Given this list of marker genes F2RL2, C3orf52, GNG3, SRSF9, MPPED2, MNT, CXXC5, PHC1, DTL, CAMK2N1, SLC18B1, HNRNPK, SHISA6, SIAH2 (siah E3 ubiquitin protein ligase 2), LCP1, PCLAF, TRIB1 (tribbles pseudokinase 1), DMXL2, CHPT1, PPM1G, JUP, DRAP1, PTBP1, DCLK3, BASP1-AS1, PTGES, MLXIP, STARD13, CCDC191, SOX30, SYNCRIP, MAFG, BAZ2B (bromodomain adjacent to zinc finger domain 2B), PEDS1, RCBTB1, USP47, RELL1, BAHD1, TMX3, LEF1, ADNP, HDHD2, DIRAS2, EEF1G, CAP2, MME, MAP3K21, MZB1, ITFG2, HMCES, ACTG1, PHF10, TRIM35 (tripartite motif containing 35, NCBI Gene Id 23087), NUP88, LIMS2, TPD52, MIR663AHG, AKAP12, TCL1A, F2RL3, HERC2P1, DCBLD1, HNRNPA2B1, RASSF6, SSRP1, AAK1, HSPD1, PLEKHB2, AEBP1, ARHGAP17, SUCLG2, HRK, MCF2L2, URB2, KCTD3, SH2D1A, UBE2M, DIMT1, NOC2L, RB1, SLC38A1, TSPAN14, FGGY, DCAF12, BEST4, NNT, BTBD3, HERC2, SOX8, TAS2R38, SMAD1, ING5, KCNJ2, THTPA, LNPEP, CAMKK2, DHX9, LONRF2, ZWINT, ENO2, IFT52, ZNF41, ANKS1A, GNAI1, TUFM, MAP1LC3C, B4GALNT2, KDM1B, CD38, MTCL2, CDK9, CREB3L2, CDHR5, NLRP6, ZMYM5, REEP3, RTN3, CACNA1I, DNAJC3, SAMHD1, HMG20B, RNF157-AS1, RYR1, CES1, ATP11C, TCF7L2, YJU2, LMTK2, ABCE1, CCDC88C, IGF2R, NET1 (neuroepithelial cell transforming 1), ELFN1, UHRF1, CLINT1, CRMP1, RGS20 (NCBI Gene Id 8601), ARRDC4, CAPRIN1, USP46, BAIAP2L1, CSF2, APCDD1, ZDBF2, SPG21 (SPG21 abhydrolase domain containing, maspardin), VEGFD, PRKAG2, GPR22, TMEM109, SERTAD2, HEXD, SLC7A6, HNRNPF, CBX3, SH3BGRL, DNAH5 (dynein axonemal heavy chain 5), ARID1B, LINC02297, PDE4D, KCTD4, GNB1 (G protein subunit beta 1), MYB, TCF4, FSD1, LAMP5, ATG101, COX19, SLC1A1, C4orf46, GLUD2, CASTOR3P, SLC30A4, H2AC6, NOS1AP, PHACTR1, CDKL1, OLIG3, PRR4, SUPT16H, TSPAN13 (tetraspanin 13), CLPP, ANKRD50, SNX27, EIF2AK3, UBXN7, SHC1, IHO1, KANK2, DIAPH1-AS1, EPB41 (erythrocyte membrane protein band 4.1), SH3BGR, ABLIM1, MED10, PPP1R2, here is a description of the gene set: Genes down-regulated in CD11b Spleen from BALBc mouse versus CD11b Tumor from BALBc mouse. Tumor growth is associated with a profound alteration of myelopoiesis, leading to recruitment of immunosuppressive cells known as myeloid-derived suppressor cells (MDSCs). Analyzing the cytokines affecting myelo-monocytic differentiation produced by various experimental tumors, we found that GM-CSF, G-CSF, and IL-6 allowed a rapid generation of MDSCs from precursors present in mouse and human bone marrow (BM). BM-MDSCs induced by GM-CSF+IL-6 possessed the highest tolerogenic activity, as revealed by the ability to impair the priming of IFN- -producing CD8+ T cells upon in vivo adoptive transfer. Moreover, adoptive transfer of syngeneic, GM-CSF+IL-6-conditioned MDSCs to diabetic mice transplanted with allogeneic pancreatic islets resulted in long term acceptance of the allograft and correction of the diabetic status. Cytokines inducing MDSCs acted on a common molecular pathway. Immunoregulatory activity of both tumor-induced and BM-derived MDSCs was entirely dependent on C/EBP transcription factor, a key component of the emergency myelopoiesis triggered by stress and inflammation. Adoptive transfer of tumor antigen-specific CD8+ T lymphocytes resulted in therapy of established tumors only in mice lacking C/EBP in myeloid compartment. These data unveil another link between inflammation and cancer and identify a novel molecular target to control tumor-induced immune suppression. We used gene expression analysis to identify those factors, secreted by tumor-infiltrating MDSC, which could drive emathopoiesis. Moreover we compare gene expression profile of tumor-induced MDSC, obtained from either the spleen and the tumor infiltrate of tumor bearing mice, and in vitro bone marrow-derived MDSC. studied in species Homo sapiens from publication Marigo I, Bosio E, Solito S, Mesa C, Fernandez A, Dolcetti L, Ugel S, Sonda N, Bicciato S, Falisi E, Calabrese F, Basso G, Zanovello P, Cozzi E, Mandruzzato S, Bronte V (PMID 20605485) Human Gene Set: GSE21927_SPLEEN_VS_TUMOR_MONOCYTE_BALBC_DN